The following is a description of a gene set: studied in species Mus musculus Mouse Gene Set: GOBP_POSITIVE_REGULATION_OF_ATP_DEPENDENT_ACTIVITY Any process that activates or increases the rate of an ATP-dependent activity., and this is the list of marker genes: Dhx9, Atp1b3 (ATPase, Na+/K+ transporting, beta 3 polypeptide), Myl4, Rgn, Msh6, Pot1b, Sumo1, Tor1aip1, Plscr1, Dnajc9, Setmar, Zc3hav1, Tor1aip2, Pfn2, Vmp1, Casr, Pot1a, Hspa2, Fgf10, Chtop, Hnrnpu, Strit1, Atp1b2 (ATPase, Na+/K+ transporting, beta 2 polypeptide), Msh2, Aldob, Msh3, Atp2a1, Ahsa1, Dnajb11, Dnajb1, Dnajb2, Ssbp1, Dnajc10, Tnnt2, Tnnt3, Dnajc24 (DnaJ heat shock protein family (Hsp40) member C24), Pfn1, Atp1b1